The following is a description of a gene set: Serial comparison between Th1 and Th17 tumor-specific cells cultured in vitro and ex vivo after transferred into sublethaly irradiated B6.PL mice. Th17-derived cells acquire Th1-like properties in vivo but maintain a distinct molecular profile. Genes up-regulated in Th1 cells 5 days post polarization: control versus stimulated with anti-CD3 and anti-CD28. from publication Muranski P, Borman ZA, Kerkar SP, Klebanoff CA, Ji Y, Sanchez-Perez L, Sukumar M, Reger RN, Yu Z, Kern SJ, Roychoudhuri R, Ferreyra GA, Shen W, Durum SK, Feigenbaum L, Palmer DC, Antony PA, Chan CC, Laurence A, Danner RL, Gattinoni L, Restifo NP (PMID 22177921) Human Gene Set: GSE26030_UNSTIM_VS_RESTIM_TH1_DAY5_POST_POLARIZATION_UP species: Homo sapiens, and this is the list of marker genes: INPP5A, BHLHE40, SLC38A2, RB1, AFP, TIRAP (NCBI Gene Id 115469), CNPY4 (NCBI Gene Id 245812), PTGER4, TMEM65, GTDC1, POLR3G, CD83, PLPP3, SP8, NID1, ANTXR2, NEUROD4, ABHD4, MBNL3, MAP2K6, GUCD1, NARF, TXNIP, CDC42BPG, ARHGAP18, SMARCA1, SLC25A24, DNAJC28, PXDC1, LYST, PTTG1IP, TAF9B, IL27RA, SLC66A2, POT1, HEXB, AP1S2, SOCS5, LANCL1, SH3PXD2A, B3GLCT, H3-5, PRKCB, CDC25B, AHNAK, PEAR1 (platelet endothelial aggregation receptor 1), SLC35D2, KLF12, DIPK1A, ACTG1, MTURN, WASF2 (NCBI Gene Id 10163), GXYLT1, CRYBG3, KLF7, RNF144A, ABCA3 (NCBI Gene Id 21), SPNS2, UVSSA, SLC16A10, PIK3CA, KBTBD11, ANO6, ADAM10, SERPINB2, THRA, ANKH, GALNT1, MAN2A2, MAPK12, TPRG1L, PFN2, HEPACAM2, AFF3, NLRC3, MTSS1 (NCBI Gene Id 9788), TSHZ1, SLC25A51, ADD3, GPR146, SMPDL3A, TTL, OSBP, CNNM3, ARHGAP6, SSPN (NCBI Gene Id 8082), FOXO1, TESK2, C2CD5, B4GALT7, MFSD6, ENTPD5, DNAAF9, ADAM19, STT3B, FTH1, SLC35F5, LRRC8C, SEC16B, ZNF467, CD200, LPIN1 (lipin 1), ING1, MSH6, MAGEE1, TCP11L2, PYGL, MCL1, SNAPC5, SLAMF1, TIFA, MMGT1, PITPNC1, TSPAN13, TNRC6C, PGAP1, FAM8A1, NCOA1, RAP2A, SNX33, RTN3, ERI2, PSD3, VOPP1, MAP3K7, L1CAM, RP9, TAX1BP3, RASSF5, UBE2H, TNS3, MAPRE2, MYADM, KDM7A, NDRG1, CACNG7, ATP1B1, SBF2, RAB23, ZDHHC20, EIF2AK3, S100PBP, BCL6, SLC41A2, AAK1, POLG2, CYB5A (cytochrome b5 type A), H1-2, TNFAIP3, CKAP4 (cytoskeleton associated protein 4), CCSAP (centriole, cilia and spindle associated protein), KCTD12, PRKAG2, KLHDC1, MICAL1, TXNDC15, UNC5CL, FRY, XPR1, TUBA1A, ATRNL1, RAB3IP, ATXN2, CMAS, KLHL14, CNKSR3, VCF1, C8orf58, PRMT2 (NCBI Gene Id 3275), NCOA6, SLC36A4, CSF2RA, RAB11FIP5, RAB31, AGO4, ALCAM, CD244, DNASE1L1, STRADB, FNTA, CEP97, ANXA5, GPR137B, GJC1, AMPD3, ZMAT3, SNX14, ZNF287, MEGF9, PDE4DIP, HBP1, RAB3A, ARL8A, SEC62, ZMIZ1, ZNF354C, SLC19A2, INSR, PJA2, ADD1